Given this list of marker genes Pdpk1, Syk, Pik3r2, Shc1, Fcer1a, Pik3cb (NCBI Gene Id 74769), Grb2, Igll1, Ms4a2, here is a description of the gene set: Reactome Pathway: Role of LAT2/NTAL/LAB on calcium mobilization electronically inferred by orthology from the curated human pathway part of: Fc epsilon receptor (FCERI) signaling studied in species Mus musculus This event has been computationally inferred from an event that has been demonstrated in another species.<p>The inference is based on the homology mapping from PANTHER. Briefly, reactions for which all involved PhysicalEntities (in input, output and catalyst) have a mapped orthologue/paralogue (for complexes at least 75% of components must have a mapping) are inferred to the other species.